Given this list of marker genes CTSD, GFRA3, MMP7, PMP22, TMEM176B, IFITM3, ARPC1B, RARRES2, MT2A, CD9, CLU, CD74, PLP1, DHRS3 (dehydrogenase/reductase 3), ISG15, IFITM2, C1R (NCBI Gene Id 791254), HLA-DPA1, HLA-DRA, GPX3, HLA-DRB5, LGALS1, IFI6, ALDH1A1, GPM6B, LGALS3BP, C1S, A2M, TUBA1A, S100A10, C3, CALM2, DEPP1, PLAT, SEMA3B, MT1X (metallothionein 1X), CRYAB, TMEM176A, ANXA1, PDK4, SERPING1, EGFL8, UCHL1, HLA-DRB1, HLA-DMA, SELENOP, S100B, WFDC2, NNMT, CTNNAL1, here is a description of the gene set: In this study, an extensive analysis was conducted to define meta-programs (MPs) capturing intra-tumor heterogeneity across a spectrum of tumor types. The approach utilized non-negative matrix factorization (NMF) to analyze each cell type separately within individual tumor samples. This involved the analysis of malignant cells, macrophages, fibroblasts, endothelial cells, epithelial cells, T-cells, and B-cells. NMF was executed with varying parameter values (K=4, 5, 6, 7, 8, 9), thereby generating 39 programs for each cell type per sample. Each NMF program was summarized by the top genes based on NMF coefficients.\nRobust MPs were then delineated for each cell type using a set of stringent criteria, including recurrence within the same tumor, similarity to programs in other tumors, and non-redundancy within a tumor. Subsequently, these robust NMF programs were clustered (per cell type) based on Jaccard similarity, leading to the identification of MPs associated with each cell type.\nTo enhance the quality of the MPs, a refinement steps were undertaken, involving the removal of MPs suspected of reflecting low-quality data (with an overrepresentation of ribosomal proteins or mitochondrial-encoded genes), single-study inclusion, or similarity to miss-annotated cell types. Genes upregulated in subsets of cells of a given type within various tumors species: Homo sapiens Human Gene Set: GAVISH_3CA_MALIGNANT_METAPROGRAM_18_INTERFERON_MHC_II_2 from publication Gavish A, Tyler M, Greenwald AC, Hoefflin R, Simkin D, Tschernichovsky R, Galili Darnell N, Somech E, Barbolin C, Antman T, Kovarsky D, Barrett T, Gonzalez Castro LN, Halder D, Chanoch-Myers R, Laffy J, Mints M, Wider A, Tal R, Spitzer A, Hara T, Raitses-Gurevich M, Stossel C, Golan T, Tirosh A, Suvà ML, Puram SV, Tirosh I (PMID 37258682)